Given this list of marker genes Lep, Plec, Slc16a1, Gh, Pyy, Chrna7, Gcg, Or4m1, Clpsl2, Npff, Npy, Mup1, Slc25a25, Mfsd11, Hsd11b2, Clps, Ucn, Trpa1 (NCBI Gene Id 277328), Mt3, Srebf1, Ghrl, Mpo (NCBI Gene Id 268460), Gm15222 (predicted gene 15222), Bbs2, Blvra, Ghsr, Cyp1a1, Mfsd5, Gpr82, Gm15441, Bbs4, Gast, Fbn1, Tmem126b, Nenf, Oprm1, Prkcg, Cps1, Ghrh, Etnppl, Pparg, Acbd7, Cartpt, Tmem135, Comt, Nucb2, Gpr180, Gfral, Ppara, Gdf15, Akt1, Atn1, Scnn1b, Bcl10, Oxt, Mc4r, Mkks, Cck, Mtor, Spx, here is a description of the gene set: studied in species Mus musculus Any process that results in a change in state or activity of a cell or an organism (in terms of movement, secretion, enzyme production, gene expression, etc.) as a result of a food stimulus; food is anything which, when taken into the body, serves to nourish or build up the tissues or to supply body heat. Mouse Gene Set: GOBP_RESPONSE_TO_FOOD